The following is a description of a gene set: Genes predicted to be targets of miRBase v22 microRNA hsa-miR-7852-3p in miRDB v6.0 with MirTarget v4 prediction scores > 80 (high confidence targets). from publication Chen Y, Wang X (PMID 31504780) species: Homo sapiens Human Gene Set: MIR7852_3P, and this is the list of marker genes: HLCS, MRPL3, FAM47E-STBD1, KAT2B, ZNF697, RBM47, CAGE1, CALB1 (calbindin 1), CLXN, ARID4A, SLC5A8, SCARA5 (NCBI Gene Id 286133), STRIP2, IL33 (NCBI Gene Id 90865), UTRN, CLEC12B, ESR1, ZNF367, IPO7, MTERF3, KLHL29, SLITRK4, PTCH2, RAP1GDS1, SANBR, PRR27, ULK2, SOAT1, SRP9, TRIM23, TDRD6, KDELR2, ARL6IP6, TASOR2, RBIS, CDYL, ZNF268, IL6ST, TCF12, RAB40B, PEG3, NR3C1, ICOS, CENPM (NCBI Gene Id 79019), RNF220, SREK1, SP4, MCTP1, NHS, PARPBP, CRTC1, RNF114, TAB2, SOX6, SPDYE3, MORC3, RAB39B, GCFC2 (NCBI Gene Id 6936), FRMD5, STBD1, MAGEA10, FRMPD3, MEDAG, MSI2, PATZ1, CIITA, HERC1 (HECT and RLD domain containing E3 ubiquitin protein ligase family member 1), ERICH1, GABRA4 (NCBI Gene Id 2557), NF1 (neurofibromin 1), ASH1L, COL15A1, JMJD1C, MIER1, RAB8B